Given this list of marker genes PIK3CD, PIK3R1, BLM, SASH3, CD70, MAGT1, PTEN, PGM3, TGFB1, CTPS1, RAC2, IL2RA, FCGR3A, CD27, TRAC, DOCK2, here is a description of the gene set: studied in species Homo sapiens Human Gene Set: HP_SEVERE_VARICELLA_ZOSTER_INFECTION Severe varicella zoster infection An unusually severe form of varicella zoster virus (VZV) infection. In the majority of the cases, especially in children, varicella is a very mild infection characterized by skin lesions, low grade fever and malaise. Severe infection is characterized by manifestations including VZV pneumonia, hepatitis, meningitis, and disseminated varicella.